The following is a description of a gene set: The directed movement of carnitine into, out of or within a cell, or between cells, by means of some agent such as a transporter or pore. Carnitine is a compound that participates in the transfer of acyl groups across the inner mitochondrial membrane. Mouse Gene Set: GOBP_CARNITINE_TRANSPORT species: Mus musculus, and this is the list of marker genes: Slc16a9, Slc25a20, Slc25a29, Slc22a4, Slc22a21, Slc22a5, Slc6a14, Slc22a1, Slc22a16